Given this list of marker genes HLA-DMA, HLA-DRB4, HLA-DOB, HLA-DOA, HLA-DQB1, HLA-DQA1, HLA-DPB1 (major histocompatibility complex, class II, DP beta 1), HLA-DRB1, HLA-DPA1, HLA-DRA, HLA-DQB2, HLA-DRB3, HLA-DMB, HLA-DRB5, CD74, HLA-DQA2, B2M, here is a description of the gene set: species: Homo sapiens A transmembrane protein complex composed of an MHC class II alpha and MHC class II beta chain, and with or without a bound peptide or polysaccharide antigen. Human Gene Set: GOCC_MHC_CLASS_II_PROTEIN_COMPLEX